The following is a description of a gene set: Neighborhood of PSMC1 proteasome (prosome, macropain) 26S subunit, ATPase, 1 in the MORF expression compendium Neighborhood of PSMC1 Human Gene Set: MORF_PSMC1 species: Homo sapiens, and this is the list of marker genes: SPTLC1 (serine palmitoyltransferase long chain base subunit 1), RAN, SEM1, PSMC4, PSMC5, SAP18, MRPS11, PPP6C, YWHAB, PITRM1, HSD17B10, CLEC18C, TBCA (tubulin folding cofactor A), ATP5MF, RAD23B, SNRPG, SEPHS2, PSMA3, SMARCD2, ADRM1, CALM1, CLTA, TM9SF1, EIF5, SNRPE, PSMB4, PPP4C, MAEA, GGCT, COX6B1, SUMO3 (NCBI Gene Id 6612), PSMB5, FAM20B, COX5A, DPM1, COX7A2, TMBIM6, POLR2G, GMFB, HMGN1, SLC7A5P1 (solute carrier family 7 member 5 pseudogene 1), ELOB, ELOC, TMEM183A (NCBI Gene Id 92703), ATOX1 (antioxidant 1 copper chaperone), MORF4L2, ARF3, GABARAPL2, ATP6V0E1, AP2M1, TSR3, CANX, AP2S1, PAF1, BBLN, TMED10, SETD3, PSMC2, RPP38, MBTPS1, STX16, CNBP, NDUFAB1, YWHAE, COX6A1, VPS72, COX4I1, ENSA, COIL, NDUFS3, DCTN2, CNIH1, CDIPT, VCP, PSMC6, BAG5, CCT2, PRMT1, HARS2, RER1, SYPL1, VTI1B, RBM4, LSM3, JTB, GATD3, PTPA, EIF3C, CCT7, SEPTIN2, COX17, GLOD4, CDK7, DNPEP, COPS5, PSMD9, MBD4, KPNA2, EIF3B, ADAR, HSBP1, DRG1, PPP2R1A, CAPNS1, SOD1, CYC1, IST1, STOML2, URM1, RNF6, EIF4E2, MYL11, PSMD7, POLR2H, SEC13, UTP18, LAMTOR5, MAD2L1BP, TMEM147, UQCRB, PSMD8, PSMC3, RAB5A, UBA1, SSR2, BUD31, ERH, PSMC1, PDCD6, ETFA, COX11, HNRNPA3P1, HSP90AA1, MTDH, VPS52, ATP5F1C, RAE1, COMMD4, YY1, ZC3H14, NDUFB1, NDUFA1, LSS, PUF60, EEF1A2, CTCF, PSMB1, HNRNPAB, ARF5, CFDP1, PSMA2, SMG7, SUMO1, SF3B2, ARHGDIA, URI1, SRP19, ATP6V1E1, PPP1R7 (protein phosphatase 1 regulatory subunit 7), TMED2, BANF1, TDG, RAD21, NDUFA2, RBM42, PPP1CA, COX7A2L, ATIC (5-aminoimidazole-4-carboxamide ribonucleotide formyltransferase/IMP cyclohydrolase), PSMA4, KARS1, FUBP1, TECR, EEF1D, CDC123, SIVA1 (SIVA1 apoptosis inducing factor), NDUFS1, NME2, BCAP31, SSNA1, RPL36AL, NEDD8, UBE4A, SRP9, HNRNPUL1, CBX3, MRPL9, ANP32B, SKP1 (NCBI Gene Id 6500), UBR5, AKT1